Given this list of marker genes Tgfb3, Lef1, Il1b, Snai1, Il6, Tcf7l2, Tbx20, Lrg1, Col1a1, Smad3, Crb2, Bmp2, Myocd, Adam8, Agt, Tgfb2, Gcnt2, Notch1, Dab2, Tgfb1i1, Foxc1, Mdk, Wwtr1, Emp2, Zfp703, Ager, Tgfbr2, Loxl2, Ctnnb1, Axin2, Tgfb1, Olfm1, Kdm1a, Smad2, Jag1, Hdac2, Sdcbp, Bcl9l, Ezh2, Bambi, Tgfbr1, Pdpn, Rgcc, Twist1, Mtor, Eng, Smad4, Bmp7, Isl1, Mad2l2, Alx1, Glipr2, Acvr1, Bmp4, Fermt2, Ptk2, here is a description of the gene set: Any process that increases the rate, frequency, or extent of epithelial to mesenchymal transition. Epithelial to mesenchymal transition is where an epithelial cell loses apical/basolateral polarity, severs intercellular adhesive junctions, degrades basement membrane components and becomes a migratory mesenchymal cell. species: Mus musculus Mouse Gene Set: GOBP_POSITIVE_REGULATION_OF_EPITHELIAL_TO_MESENCHYMAL_TRANSITION